The following is a description of a gene set: species: Homo sapiens We explored whether the five previously reported molecular subtypes in breast cancer show a preference for organ-specific relapse and searched for molecular pathways involved. The intrinsic gene list describing the subtypes was used to classify 344 primary breast tumors of lymph node-negative patients. Fisher exact tests were used to determine the association between a tumor subtype and a particular site of distant relapse in these patients who only received local treatment. Modulated genes and pathways were identified in the various groups using Significance Analysis of Microarrays and Global Testing. Bone relapse patients were most abundant in the luminal subtypes but were found less than expected in the basal subtype. The reverse was true for lung and brain relapse patients with the remark that absence of lung relapse was luminal A specific. Finally, a pleura relapse, although rare, was found almost exclusively in both luminal subtypes. Many differentially expressed genes were identified, of which several were in common in a subtype and the site to which the subtype preferentially relapsed. WNT signaling was up-regulated in the basal subtype and in brain-specific relapse, and down-modulated in the luminal B subtype and in bone-specific relapse. Focal adhesion was found up-regulated in the luminal A subtype but down-regulated in lung relapse. The five major molecular subtypes in breast cancer are evidently different with regard to their ability to metastasize to distant organ(s), and share biological features and pathways with their preferred distant metastatic site. Human Gene Set: SMID_BREAST_CANCER_RELAPSE_IN_LIVER_UP Genes up-regulated in liver relapse of breast cancer. from publication Smid M, Wang Y, Zhang Y, Sieuwerts AM, Yu J, Klijn JG, Foekens JA, Martens JW (PMID 18451135), and this is the list of marker genes: FGB, S100A8, PPP1R1A, CLIC3, KYNU, CRLF1